The following is a description of a gene set: studied in species Homo sapiens Any process that increases the frequency, rate or extent of uterine smooth muscle contraction. Human Gene Set: GOBP_POSITIVE_REGULATION_OF_UTERINE_SMOOTH_MUSCLE_CONTRACTION, and this is the list of marker genes: TACR1 (NCBI Gene Id 6869), OXT, TACR3, ABAT, ADRA2B, TACR2, GPER1